The following is a description of a gene set: Genes down-regulated in peripheral blood mononuclear cell 3d vs 0d in unknown after exposure to YF-Vax/Stamaril, time point 3D Correlates of immune-mediated protection to most viral and cancer vaccines are still unknown. This impedes the development of novel vaccines to incurable diseases such as HIV and cancer. In this study, we have used functional genomics and polychromatic flow cytometry to define the signature of the immune response to the yellow fever (YF) vaccine 17D (YF17D) in a cohort of 40 volunteers followed for up to 1 yr after vaccination. We show that immunization with YF17D leads to an integrated immune response that includes several effector arms of innate immunity, including complement, the inflammasome, and interferons, as well as adaptive immunity as shown by an early T cell response followed by a brisk and variable B cell response. Development of these responses is preceded, as demonstrated in three independent vaccination trials and in a novel in vitro system of primary immune responses (modular immune in vitro construct system), by the coordinated up-regulation of transcripts for specific transcription factors, including STAT1, IRF7, and ETS2, which are upstream of the different effector arms of the immune response. These results clearly show that the immune response to a strong vaccine is preceded by coordinated induction of master transcription factors that lead to the development of a broad, polyfunctional, and persistent immune response that integrates all effector cells of the immune system. species: Homo sapiens Human Gene Set: GAUCHER_PBMC_YF_VAX_STAMARIL_UNKNOWN_AGE_3DY_DN from publication Gaucher D, Therrien R, Kettaf N, Angermann BR, Boucher G, Filali-Mouhim A, Moser JM, Mehta RS, Drake DR 3rd, Castro E, Akondy R, Rinfret A, Yassine-Diab B, Said EA, Chouikh Y, Cameron MJ, Clum R, Kelvin D, Somogyi R, Greller LD, Balderas RS, Wilkinson P, Pantaleo G, Tartaglia J, Haddad EK, Sékaly RP (PMID 19047440), and this is the list of marker genes: CPD, ELAPOR1, RPL3, ZNF217, FAU, EIF3L, RPL35A, ALPL, RPL27, ORM1, KLHDC2, CAMK1D (NCBI Gene Id 57118), RPS14, GLS, RPS6KA5, DDX3X, VNN2, TXNDC12, EIF4B, TMCO3, HYCC2, MPZL1, TOMM7, RPS8, IRS2, ICAM3, FCRLA, RPL4, ALKBH7, RPL22, NIBAN1, SEL1L3, RPS20, EEF1B2, EEF2, NAMPT, MYADM, PI3, TP53INP2, GNG7, STAT5B, PYGL (NCBI Gene Id 5836), EIF3F, BCL6, RPS6, KLHL2, CD46, TBC1D14, RPS27A, RBM47, ARAP3, TOPORS, C12orf57, ZNF281, RPS29, ATOSA, RPLP0, FBL, CBX7, RPS5, NFXL1, PABPC4, ERGIC1, OSBPL8, H1-2, KBTBD7, PTOV1, RPL5, CREB5, TMX4, RUBCNL, TBL1X, RFLNB, GPR183, EEF1A1, SNHG29, WLS, GMCL1, RPS3, RPS18, RPL18, RPS25, STMN3, NARF, ABCC5, PRKDC, GPR162, CDK19, RPS13, SORL1, TPT1, H4C3, CPPED1, IMPA2, PPM1F, ABHD5, LMBRD1, ADGRE3, RPL30, FOXO1, BANK1, RPS4X, RPL13A (ribosomal protein L13a), RPL37A